The following is a description of a gene set: studied in species Mus musculus Any process that modulates the frequency, rate or extent of mRNA 3'-end processing, any process involved in forming the mature 3' end of an mRNA molecule. Mouse Gene Set: GOBP_REGULATION_OF_MRNA_3_END_PROCESSING, and this is the list of marker genes: Ahcyl1, Cdk9, Cpeb1, Ncbp1, Zfp36l1, Ccnb1, Dhx36, Cdc73, Pabpc2, Fip1l1, Pabpn1